Given this list of marker genes Pck1, H2-Ea, Fgl2, Bcl6, Tnfsf4, Il23a, Cd46, here is a description of the gene set: Any process that modulates the frequency, rate, or extent of memory T cell differentiation. species: Mus musculus Mouse Gene Set: GOBP_REGULATION_OF_MEMORY_T_CELL_DIFFERENTIATION